The following is a description of a gene set: part of: Biosynthesis of maresins species: Mus musculus electronically inferred by orthology from the curated human pathway Reactome Pathway: Biosynthesis of maresin-like SPMs This event has been computationally inferred from an event that has been demonstrated in another species.<p>The inference is based on the homology mapping from PANTHER. Briefly, reactions for which all involved PhysicalEntities (in input, output and catalyst) have a mapped orthologue/paralogue (for complexes at least 75% of components must have a mapping) are inferred to the other species., and this is the list of marker genes: Cyp3a11, Cyp3a41b, Cyp3a25, Cyp1a2, Cyp2c65, Cyp3a57, Cyp3a41a, Cyp3a44, Cyp2d22, Cyp3a16, Cyp3a13, Cyp2c66, Cyp2e1